The following is a description of a gene set: Human Gene Set: GOBP_REGULATION_OF_OXIDATIVE_PHOSPHORYLATION Any process that modulates the frequency, rate or extent of the chemical reactions and pathways resulting in the phosphorylation of ADP to ATP that accompanies the oxidation of a metabolite through the operation of the respiratory chain. Oxidation of compounds establishes a proton gradient across the membrane, providing the energy for ATP synthesis. species: Homo sapiens, and this is the list of marker genes: ATP7A, MIR210, TNF, TMEM135, NUPR1, UQCC2, MLXIPL, MLDHR, RHOA, AK4, ABCD1, MACROH2A1, ETFRF1 (electron transfer flavoprotein regulatory factor 1), PPIF, PINK1, VCP, TEFM, SLC25A23, SLC25A33, DNAJC15, SIRT3, SHMT2, ACTN3, SNCA